Given this list of marker genes MEF2A, MAPK3, VRK3, RPS6KA1 (NCBI Gene Id 6195), RPS6KA5, MEF2C, MAPK11, RPS6KA3, RPS6KA2 (NCBI Gene Id 6196), PPP2R1A, MAPK14 (NCBI Gene Id 1432), PPP2R1B, DUSP3, DUSP4, DUSP6, PPP2CB (protein phosphatase 2 catalytic subunit beta), MAPK1, PPP2CA, ELK1, MAPK7, PPP2R5D, DUSP7 (NCBI Gene Id 1849), here is a description of the gene set: part of: MAPK targets/ Nuclear events mediated by MAP kinases; Nuclear Events (kinase and transcription factor activation) studied in species Homo sapiens Reactome Pathway: ERK/MAPK targets ERK/MAPK kinases have a number of targets within the nucleus, usually transcription factors or other kinases. The best known targets, ELK1, ETS1, ATF2, MITF, MAPKAPK2, MSK1, RSK1/2/3 and MEF2 are annotated here.